Given this list of marker genes CA8, CA6, SDHC, ACADM, AMT, HAL, ACADS, GLUD1, ACADL, DHODH, DPYD, CTH, ACADVL, SRD5A2, CA5A, ACADSB, CA2, CPS1, here is a description of the gene set: Human Gene Set: MODULE_294 studied in species Homo sapiens Genes in the cancer module 294.